Given this list of marker genes Atrx, Gmnc, Rad21l, Smad4, Mcidas, Scaper (NCBI Gene Id 78726), Adrm1, Rec8, Rnase10, Tbc1d20, Kif18a, Ubb, Wdr48, Gata4, Ccno, Dnaaf3 (dynein, axonemal assembly factor 3), Inhbb, Ar, Ing2, Spata2, Adgrg1, Fer, Wt1, Jmjd1c, Odad3, Brip1, Spink2, Lhcgr, here is a description of the gene set: studied in species Mus musculus The reproductive developmental process whose specific outcome is the progression of the seminiferous tubule over time, from its formation to the mature structure. Seminiferous tubules are ducts located in the testicles, and are the specific location of meiosis, and the subsequent creation of gametes, namely spermatozoa. Mouse Gene Set: GOBP_SEMINIFEROUS_TUBULE_DEVELOPMENT